Given this list of marker genes PEX1, KIAA0586, NEK8, KCNQ1OT1, CSPP1, MPDU1, CDKN1C, KCNQ1, INVS, ETFDH, ETFB, PEX2, CD96, IGF2, ETFA, PIGQ, SKIC3 (SKI3 subunit of superkiller complex), CEP290, here is a description of the gene set: Human Gene Set: HP_RENAL_CORTICAL_CYSTS Renal cortical cysts Cysts of the cortex of the kidney. studied in species Homo sapiens